Given this list of marker genes CD59, SEM1, RPL10, PSMB8 (proteasome 20S subunit beta 8), PRDX1 (NCBI Gene Id 5052), RPL27A, CCN1, NFKBIA, TPR, MAN2A1, CXCL1, KIT, MYL6, PRELID3B, NFKB1, CMPK1 (cytidine/uridine monophosphate kinase 1), PCMT1, ELOVL5, CDC34, GINS2, RPS8, PLP2, PPP1R10, TGFBR3, ACLY, ITGB2, TSPAN3, KEL, FBN1, OAZ1, SOD2, RPS23, EEF2, CCL2, FAM50A (family with sequence similarity 50 member A), IL32, CCNC, PTGES, TUBA4A, EBP, GADD45A, NCL, DROSHA, KALRN, GDI2, MYL12A, SF3A3, PSMB7, TNIP1, SNX12, here is a description of the gene set: Genes up-regulated in HeLa cells (cervical carcinoma) at 4 h after stimulation with TNF. Tumor necrosis factor alpha (TNF alpha) is a proinflammatory cytokine with important roles in regulating inflammatory responses as well as cell cycle proliferation and apoptosis. Although TNFalpha stimulates apoptosis, it also activates the transcription factor NF-kappa B, and studies have shown that inhibition of NF-kappa B potentiates the cytotoxicity of TNFalpha. Since several chemotherapy agents act like TNFalpha to both promote apoptosis and activate NF-kappa B, understanding the role of NF-kappa B in suppressing apoptosis may have significant clinical applications. To understand the effects of stimulation with TNFalpha and the role of NF-kappa B in regulating this response, a 23k human cDNA microarray was used to screen TNFalpha-inducible genes in HeLa cells. Real-time PCR verified expression changes in 16 of these genes and revealed three distinct temporal patterns of expression after TNFalpha stimulation. Using RNA interference to disrupt expression of the p65 subunit of NF-kappa B, all but two of the genes were shown to depend on this transcription factor for their expression, which correlated well with the existence of NF-kappa B binding sites in most of their promoters. Inflammatory, proapoptotic, and antiapoptotic genes were all shown to be regulated by NF-kappa B, demonstrating the wide variety of targets activated by NF-kappa B signaling and the necessity of differentiating among these genes for therapeutic purposes. from publication Zhou A, Scoggin S, Gaynor RB, Williams NS (PMID 12673210) Human Gene Set: ZHOU_TNF_SIGNALING_4HR studied in species Homo sapiens